The following is a description of a gene set: studied in species Homo sapiens Human Gene Set: GOBP_PHAGOCYTOSIS_ENGULFMENT The internalization of bacteria, immune complexes and other particulate matter or of an apoptotic cell by phagocytosis, including the membrane and cytoskeletal processes required, which involves one of three mechanisms: zippering of pseudopods around a target via repeated receptor-ligand interactions, sinking of the target directly into plasma membrane of the phagocytosing cell, or induced uptake via an enhanced membrane ruffling of the phagocytosing cell similar to macropinocytosis., and this is the list of marker genes: AIF1, XKR6, ANO6, ALOX15, ABCA1, ARHGAP12, ITGB2, TREM2, STAP1, MSR1, ITGA2, CD36, XKR4, ABCA7, SH3BP1, THBS1, CLCN3, XKR8, GSN, NCKAP1L, TIMD4, ADGRB1, FCER1G, APPL2, C3, GULP1, GATA2, PLCG2, ARHGAP25, ITGAM, HAVCR1, MYH9, DOCK1, CD300A, FCGR2B, BECN1, RAB31, F2RL1, CLCN2, MARCO, XKR7, RAC1, FCGR1A, CDC42, VAMP7, BIN2, ELMO1, MEGF10